Given this list of marker genes GAPVD1, WDR4, PSMC3IP, GPRC5C, PDCD5, RPLP1, JUN, PRKRA, VAV3, XRCC5, CTSA, TBC1D10B, VCP, TRMT112, CCNK, SEC23A, RGS6, PPP2R5A, USP6NL, ACAP1, ERRFI1, RASA1, ARHGAP33, TBC1D5, TAOK1, RABGAP1L, ACAP3, FRS2, NANOS2, TBC1D22A (NCBI Gene Id 25771), RAB3GAP2, EFNA5, APOC1, GUCA1C (NCBI Gene Id 9626), TBCD, NANOS1, ARHGAP4, CASP1, MADD, RASA3, PAK2, PCOLCE, RGS17, NCSTN, ARHGAP15, SIRT1, TAGAP, RACGAP1, SH3PXD2B, BTK, APOH, ACSL1, RASAL3, ABI1, CTSH, EPGN, CALM2, APOA4, ARHGAP1, ARHGAP21, ARHGAP20, CASP9, NOXO1, TBC1D13, LGMN, APOC2 (NCBI Gene Id 344), ARHGDIA, NPRL2, CDKN1B, RBCK1, GMFB, CHN1, DAXX, MMP17 (matrix metallopeptidase 17), TBC1D4, DCP1B, B3GAT3, MIA2, PPP4R3B, FNTB, RASA2, ENTREP1, CDC20B, ERBB3, AXIN1 (NCBI Gene Id 8312), STK4, ALS2, STK3, DAD1, GIT2, TBC1D14, GNAS, TBC1D24, FAM13B, AGAP7P, BCAS3, RGS9, TIMM50, RGS20 (NCBI Gene Id 8601), CKS2, MGST2, DNMT3L, VRK3, MSTN, DOCK7 (NCBI Gene Id 85440), TSC2, SYNGAP1, NUPR1, ARHGEF11, HBEGF, EGF, CHML, GHRL, MTCP1, APOA5, HACD3, ALS2CL, NRG1, ARL1, DBNL, NRP1, C9orf72, TBC1D3L, TBC1D26, DELE1, RGPD8, TBC1D7, ARHGEF6, ARAP2, TEFM, NCOR2, RP2, ALK, KAT2B, ERCC5, RGS10, DGKQ, STARD13, TBC1D9, GDI2, PARP8, TRIB3, DAZAP2 (DAZ associated protein 2), APP, NDUFA13, RALGAPB, PREX1, EVI5L, EPO (erythropoietin), ALOX5AP, MALT1, TOM1L1, RGPD4, PCOLCE2, NCF4, ALKAL2, MAP3K12, WDR41, RALGAPA1, NCF1C, BNIP2, PLEKHG6, AGAP11, EEF1A1, AGFG2, NANOS3, AGAP2, COQ8A, NOXA1, SIPA1, IL6ST, RAP1GAP, CAV1, RAPGEF2, RAP1GAP2, SIPA1L2, MMP15, ELMOD2, PYCARD, ARHGAP30, PARP6, PDE8A, PLXNB1, STXBP5, MAP3K13 (mitogen-activated protein kinase kinase kinase 13), ATP2A3, RAB3GAP1, CALM1, NLRP3, SDHAF4, RIN3 (NCBI Gene Id 79952), CCNT2, AGAP4, PIN1, DBF4B, TBC1D20, MT3, DAB2IP, CCL3, PDPK1, RGPD5, NBN, PPP2R5D, ARHGDIB, FN1, GUCA1B, PDGFRA, AGAP1, EBAG9, TRIM23, RASA4B, SPDYA, EIF5, ARHGAP8, MMP16, PRKCE, BEX3 (brain expressed X-linked 3), PREX2, GDF2, MAL, NRDC, CDKN1A, PPP4R3A, SRC, ACVR2B, CDK5R1, PHACTR4, IQGAP1, PARP16, STRADB, BMP4, HTR2A, UBE2N, COQ9, RICTOR, IQGAP2, STRADA (NCBI Gene Id 92335), WDR20, FURIN, CASP3, STRIT1, ARRB1, PPP2R5C, RGS3, TBC1D21, SIPA1L3, ARHGEF15 (NCBI Gene Id 80081), TBC1D12, ARHGAP31, TBC1D9B, ARHGAP26, NEK9, ELMOD1, ANGPT4, CCL8, RABEP1, MYO9A, MOB1A, FAM13A, BTRC, MYO9B, RALBP1, SLC39A10, WRNIP1, PSME3, RFC1, WDR48, ST20, ERCC6, ARHGAP36, FYN, GRM5, SVBP, TBC1D3D, PPP2R5E, CHN2 (chimerin 2), FAM20A, ASAP3, FBXW7, AGAP9, TBC1D10C, TBC1D2B, RABGAP1, ARHGAP45, TIAM2, TBC1D3K, PIM1, CASP8AP2, CLPS, AMBRA1, DCP1A, ARFGEF1, OCRL, MAPK8IP2, AREG, RGS12, ANKRD27 (ankyrin repeat domain 27), PARP1, GARNL3, IGFBP3 (insulin like growth factor binding protein 3), SLC27A1, RALGAPA2, APAF1, ETAA1, FZR1, BAD, TBC1D15, TIPRL, ARHGAP42 (NCBI Gene Id 83935), ARHGAP5, PSAP, ARHGAP29, PSME2, CKS1B, ARHGEF1, PIK3CA, PIK3R1, DEPDC5, ARHGAP35, ALDH1A1, RCVRN, PINK1, PEX12, EREG, ARHGAP12, MAP2K1, NKX3-1, GREM1, GUCA1ANB-GUCA1A, TGFA, DLC1, MOB1B, GNA12, DEPTOR (DEP domain containing MTOR interacting protein), ARAP1, SIPA1L1, CHM, ARHGAP39, PLAA, RGPD1, HSP90AB1, LLGL2, TBC1D17, CALM3, ARHGEF19, CDC42EP2, TPX2, DMWD (DM1 locus, WD repeat containing), ARHGAP28, GPIHBP1, CLPSL2, RINL, ELMOD3, CXCL1, PDGFB, LAMTOR3, ACAP2, RASAL2, NF1, NCS1, CD33, FLCN, ASAP1, GMFG, ARFGAP3, RGS7, AGT, EGFR (NCBI Gene Id 1956), SEC23B, ADIPOQ (adiponectin, C1Q and collagen domain containing), RGPD2, APH1A, VCAN, ATG13, SYDE2, MOB3A, PDGFRB, POLG2, ARHGAP9, IGF2, TBC1D3I, DEPDC1, ADAP1, PRKAG2, MID1IP1 (MID1 interacting protein 1), APOA2, ARFGAP2, TNKS1BP1, SUZ12, NLRP12, ARHGDIG, FXN, DOCK5, MAP2K2, SAE1, RACK1, TBC1D1, TAOK2, CCND3, GUCA2B, APOA1, DDOST, SFRP2, DNM1L, CCL5, SH3PXD2A, PARK7, MAP3K20 (NCBI Gene Id 51784), CD24, RIN1 (Ras and Rab interactor 1), AJUBA, DDX3X, ADAP2, TBC1D10A, RGS14, TGFB1, TBC1D19, EVI5, MLST8, BMP7, GNB5, ASAP2, LCK, FNTA, TBC1D3B, GTF2F1, MOB3C, VEGFA, CCNT1, SMAP1, STARD8, ABHD5, LTC4S, SMAP2, SAV1, TBC1D3G, SAMD15 (sterile alpha motif domain containing 15), GRTP1, MMP24, RGS11, VSIR, PSME4, PPP1R15A, CCND1, ARHGAP10, STX4, TBC1D3F, SRGAP3, PPP1R12B, GMIP, LLGL1, ARHGAP11A, SRGAP1, ABL2, LTK, FNIP1, CBX8 (chromobox 8), HMGB1, RABEP2, CFLAR, GNAQ, RAD50, PTPA, RGS4, SPRY2, RGPD3, BCL10, WNT11, NGF, TBC1D2, GPRC5D, AGAP3, GDI1, SLX4, MSH2, DEPDC1B, ARF4, TBC1D8B, RIN2, ARHGAP32, LTF, PSME1, CARD8 (caspase recruitment domain family member 8), AGFG1, PLCB1, ECT2, ARHGAP23, FERMT2, NLRC4, PSMD14, TBC1D30, LRCOL1, MOB3B, RASAL1, GPRC5B, MNAT1, NCF1B, CCNB1, BMP2, TBC1D16, NAA16, PCNA, AGAP5, INSR, RASGRP3, ARHGAP25, SMCR8, GIT1, ARHGAP11B, ARHGAP40, GDF10, IRGM, CD40LG, TAB1, TIFAB, NLRP1, PITRM1, GPR158, BCR, GCN1, ARHGAP22, TGFBR2, CAB39, FAM47E, TBC1D25, DOCK3, NAA15, DPM3, SH3BP1, BMI1, AZIN2, PLEK, RGS16, GHR, CDK5R2, PTEN, TREM2, EED, RGPD6, DOCK4, DUSP19, ARHGEF10L, IGF1, OPHN1, TANK, NAA25, MAPRE3, RGS8, RAMAC, STK11, SSBP1, BRPF1, GUCA2A, HSPB2, CCND2, UBE2L3, ABR, POR, RGS1, MTSS2, RPTOR, LARS1, PRSS22, ARFGAP1, SGSM1, GUCA1A, ARHGAP44, NRG3, SYDE1, SGSM2, ARHGEF16, NCKAP1L, NCF2, TCL1A, RGS18, STAP1, HSPD1, PPP2R5B (NCBI Gene Id 5526), CWF19L1, STXBP5L, RASA4, MLH1, RANBP2, ARHGAP17, TBC1D3H, TIMELESS, ARHGAP19, DPM2, APH1B, MARK2, CTSC, LRRK2, CAB39L, ARHGAP18, RGS2, DOCK2, IL2, TBC1D8, ARHGAP6, APOE, TBC1D22B, THY1, SERINC1, TBC1D3, ARHGAP27, ARHGEF12, DOCK1, IQGAP3, TBCK, HTR2B, RANGAP1, PPP4R3C, HRAS, MOB2 (NCBI Gene Id 81532), RANBP1, NCF1, CLPSL1, AIM2, ABL1, ARAP3, SRGAP2, CLPX, AGAP6, ITGA1, SERINC2, FBLN1, TCL1B, TBC1D3E, BTC, ROCK2, BCL2L13, TOPBP1, RGS5, ALKAL1, KRTCAP2, WNK1, RGCC, CDC20, VPS9D1, GPRC5A, ADGRB3, AZIN1, COX17, NOD1, SOS1, TBC1D3C, PRKCD, CCDC88A, ADRM1, RAF1, ARHGAP24, AFAP1L2, RING1 (ring finger protein 1), SGSM3, RHEB (NCBI Gene Id 6009), PSENEN, GM2A, NPRL3, DBF4, MAPK12 (NCBI Gene Id 6300), here is a description of the gene set: species: Homo sapiens Human Gene Set: GOMF_ENZYME_ACTIVATOR_ACTIVITY Binds to and increases the activity of an enzyme.